The following is a description of a gene set: Human Gene Set: REACTOME_ACTIVATED_NTRK2_SIGNALS_THROUGH_PI3K Activated NTRK2 signals through PI3K studied in species Homo sapiens, and this is the list of marker genes: BDNF, NTRK2, GAB1, PIK3CA, GRB2, PIK3R1, NTF4